The following is a description of a gene set: Mouse Gene Set: GOBP_POSITIVE_REGULATION_OF_KILLING_OF_CELLS_OF_ANOTHER_ORGANISM Any process that activates or increases the frequency, rate or extent of the killing by an organism of cells in another organism. species: Mus musculus, and this is the list of marker genes: Arg1, Syk, Prf1, F2rl1, Pomc, Cxcl1, Nos2, Clec7a, Ifng, Fcer2a